Given this list of marker genes Ripk2, Magea5, Bcl2l10, Bfar, Nlrc4, Fadd, Nlrp2, Magea8 (NCBI Gene Id 17144), Magea3, Ctsg, Riok3, Nol3, Magea9, here is a description of the gene set: Binding to a caspase family protein. species: Mus musculus Mouse Gene Set: GOMF_CASPASE_BINDING